The following is a description of a gene set: Human Gene Set: GOBP_REGULATION_OF_NEUROINFLAMMATORY_RESPONSE Any process that modulates the frequency, rate or extent of neuroinflammatory response. species: Homo sapiens, and this is the list of marker genes: TREM2, MMP9, MIR206, IGF1, IL33, TTBK1, DAGLA, STAP1, CX3CL1, MIR195, CTSC, SBNO1, MIR181B1, MMP3, NUPR1, CALHM2, LDLR, CST7, IL6 (interleukin 6), NR1D1, SPHK1, TNF, PTGS2, TAFA3, CD200R1, IL1B, MIR128-1 (NCBI Gene Id 406915), CD200R1L, MMP8, LRRK2, MIR181C, SYT11, MIR26A1, MIR142, CD200, GRN, CCL3, PTPRC, PLCG2, IL4, TNFRSF1B, IL18